The following is a description of a gene set: studied in species Mus musculus Genes in a cCDNA library from hematopoietic stem cells (HSC) after subtraction of lineage-specific markers. from publication Park IK, He Y, Lin F, Laerum OD, Tian Q, Bumgarner R, Klug CA, Li K, Kuhr C, Doyle MJ, Xie T, Schummer M, Sun Y, Goldsmith A, Clarke MF, Weissman IL, Hood L, Li L (PMID 11781229) Human Gene Set: PARK_HSC_MARKERS Hematopoietic stem cells (HSCs) have self-renewal capacity and multilineage developmental potentials. The molecular mechanisms that control the self-renewal of HSCs are still largely unknown. Here, a systematic approach using bioinformatics and array hybridization techniques to analyze gene expression profiles in HSCs is described. To enrich mRNAs predominantly expressed in uncommitted cell lineages, 54 000 cDNA clones generated from a highly enriched population of HSCs and a mixed population of stem and early multipotent progenitor (MPP) cells were arrayed on nylon membranes (macroarray or high-density array), and subtracted with cDNA probes derived from mature lineage cells including spleen, thymus, and bone marrow. Five thousand cDNA clones with very low hybridization signals were selected for sequencing and further analysis using microarrays on glass slides. Two populations of cells, HSCs and MPP cells, were compared for differential gene expression using microarray analysis. HSCs have the ability to self-renew, while MPP cells have lost the capacity for self-renewal. A large number of genes that were differentially expressed by enriched populations of HSCs and MPP cells were identified. These included transcription factors, signaling molecules, and previously unknown genes., and this is the list of marker genes: PARK7, CLK4, MEA1, ARL6IP1, MECOM, BCL11A, ANKRD17, SSRP1, CCNH, TLK2, CD34, MEIS1, PCM1, CCL3, LYN, NFE2, ARPC1A, RBBP6, FLT3LG (NCBI Gene Id 2323), ZFAND5, KIT, ELF1, RASA1, RGS2, NOTCH1, CD24, LAPTM5 (NCBI Gene Id 7805), SDF4, DMXL1, NKG7, VSX2, BMI1, LSP1, MTCP1, TCF4, SRSF2, LPCAT3, SPAG9, ASH1L (NCBI Gene Id 55870), WNK1, CCNDBP1, SLC25A39, MCL1, AURKB